The following is a description of a gene set: species: Mus musculus DNA microarrays are powerful tools for the analysis of gene expression on a genomic scale. The importance of individual regulatory events for the process under study can however not be deduced unequivocally without additional experiments. We devised a strategy to identify central regulators of cancer drug responses by combining the results of microarray experiments with efficient methods for phenotypic testing of candidate genes. We exposed murine FL5.12 pro-B cells to cisplatin, camptothecin, methotrexate or paclitaxel, respectively and analysed the patterns of gene expression with cDNA microarrays. Drug-specific regulatory events as well as intersections between different apoptotic pathways, including previously studied responses to staurosporine and interleukin-3 (IL-3) deprivation, were identified. Genes shared by at least three pathways were chosen for further analysis. Ectopic expression of three such genes, TEAP, GP49B, and Lipin1 was found to have an anti-proliferative effect on pro-B cells. Interestingly, we identified hemoglobin alpha as a strong pro-apoptotic regulator. While hemoglobin-expressing cells were growing normally in the presence of IL-3, they displayed accelerated apoptosis with similar kinetics as Bax overexpressing cells upon IL-3 removal. The pro-apoptotic effect of hemoglobin was suppressed by Bcl-2 and was characterized by enhanced stimulation of caspase activity. Genes specifically up-regulated in FL5.12 cells (pro-B lymphocyte) by camptothecin. Human Gene Set: BRACHAT_RESPONSE_TO_CAMPTOTHECIN_UP from publication Brachat A, Pierrat B, Xynos A, Brecht K, Simonen M, Brüngger A, Heim J (PMID 12447701), and this is the list of marker genes: ULK1, TRAFD1, TXNIP, SERTAD1, PMM1, TOB1, LPIN1, GRB10, NECTIN4, CD53, TMEM185A, C1R (complement C1r), ZFP36L1, NUDCD2, PIERCE1 (NCBI Gene Id 138162), BTG2, H2AJ, CDKN1A, CCNG1, TPP1, EI24, TP53INP1, CARHSP1, CBS, CSRNP2, LRRC2